Given this list of marker genes SCNN1A, PRKACA, HYAL2, CYP11B2, MYO5B, EXT2, AQP2, GNAS, CYP4F12, AVP, CYP4F2, AKR1B1, INPP5K, ATP6V1B1, PRKACB, PRKACG, CFTR, AQP3, BPIFA1, WFS1, ADCY6, AQP4, UMOD, CYP4A11, AQP6, AQP1, SCNN1B, SCNN1G, TRPV4, EXT1, AKAP11, HAS2, MLLT6, here is a description of the gene set: A chemical homeostatic process involved in the maintenance of a steady state level of water within extracellular body fluids, such as blood, xylem or phloem, of a multicellular organism. This is distinct from maintenance of cellular homeostasis, which occurs within a cell. Human Gene Set: GOBP_MULTICELLULAR_ORGANISMAL_LEVEL_WATER_HOMEOSTASIS studied in species Homo sapiens